The following is a description of a gene set: studied in species Mus musculus Catalysis of the transfer of a mannosyl group to an acceptor molecule, typically another carbohydrate or a lipid. Mouse Gene Set: GOMF_MANNOSYLTRANSFERASE_ACTIVITY, and this is the list of marker genes: Pomt2, Dpm2, Alg1, Tmtc1, Alg3, Alg11, Dpy19l1, Alg12, Dpy19l3, Dpm1, Pomt1, Alg9, Pigb, Tmtc3, Dpy19l2, Tmem260, Alg2, Pigm, Dpy19l4, Tmtc2, Gtdc1, Pigz (NCBI Gene Id 239827), Pigv, Tmtc4